The following is a description of a gene set: Peroneal muscle atrophy Atrophy of the peroneous muscles, peroneus longus (also known as Fibularis longus), Peroneus brevis (also known as fibularis brevis, and Peroneus tertius (also known as fibularis tertius). species: Homo sapiens Human Gene Set: HP_PERONEAL_MUSCLE_ATROPHY, and this is the list of marker genes: LMNA, TRPV4, TTN, DES, ANO5, SACS, HINT1, PMP22, REEP1, WASHC5, VPS13A, ITPR1